Given this list of marker genes ELANE, NOTCH2NLC, NOTCH2NLB, NOTCH2NLR, NOTCH2NLA, here is a description of the gene set: species: Homo sapiens Expression of NOTCH2NL genes Human Gene Set: REACTOME_EXPRESSION_OF_NOTCH2NL_GENES